The following is a description of a gene set: The dense covering of microvilli on the apical surface of an epithelial cell in tissues such as the intestine, kidney, and choroid plexus; the microvilli aid absorption by increasing the surface area of the cell. Mouse Gene Set: GOCC_BRUSH_BORDER studied in species Mus musculus, and this is the list of marker genes: Pls1, Myo1a, Pcmt1, Slc20a2, Cltrn, Slc17a4, Gna13, Cubn, Diaph1, Slc7a9, Hsp90ab1, Aqp1, Slc28a1, Lct, Ezr, Atp8b1, Slc6a18, Ptger3, Myo1b, Tpm3-rs7, Myo7b, Vcl, Myl6, Nherf4, Scin, Slc34a3, Cd36, Slc5a2, Kcnk1, Myh11 (myosin, heavy polypeptide 11, smooth muscle), Myo18a, Abcg2, Slc23a1, Abcg3, Slc19a1, Hsp90aa1, Drd5, Slc3a1, Shank2, Actn1, Slc5a1, Dcxr, Myh9, Npc1l1 (NCBI Gene Id 278378), Myo1e, Rapgef4, Havcr1, Slc46a1, Slc6a14, Anks4b, Itln1, Vil1, Ace, Snx5, Abcc2, Myo1c, Atp6v0a4, Prkci (NCBI Gene Id 99620), Pld2, Slc22a5, Ddr1, Mme, Myo5b, Actn3, Slc2a2, Rgs19, Gna12, Slc22a12, Myo1d, Gipc1, Folr1 (NCBI Gene Id 14275), Prkcb, Trpm6, Soat2, Slc5a8, Myo6, Myh10, Ralgds, Pemt, Sis, Slc6a19, Car4, Plb1, Capza2, Capza1, Add3, Slc15a1, Slc28a2, Itpr3, Atp7a, Akp3, Slc27a4, Myl12b, Lrp2, Flna, Eps8, Treh, Actr3, Aqp7 (aquaporin 7), Slc5a6, Slc28a3, Slc11a2, Mttp, Slc26a6, Dnm1l, Cybrd1, Nppa, Dab1, Myh14, Abcb1a, Cdhr2, Aqp8, Capzb, Ush1c, Enpep, Espn, Pik3cb, Lctl, Anpep, Slc38a2, Slc26a4, Flii, Actb, Scart1, Ace2, Slc6a20b, Slc9a2, Amn, Rapgef3, Slc34a2, Slc22a21, Lima1, Pex19, Prom1, Slc9a3, Pdzk1, Nherf1, Cgn, Slc7a11, Coro2a, Mfsd10, Slco1a5, Flnb, Slc26a3 (NCBI Gene Id 80590), Pth1r, Plec, Slc34a1, Cdhr5, B4galt1